The following is a description of a gene set: species: Homo sapiens from publication Chen Y, Wang X (PMID 31504780) Genes predicted to be targets of miRBase v22 microRNA hsa-miR-519a-2-5p, hsa-miR-520b-5p in miRDB v6.0 with MirTarget v4 prediction scores > 80 (high confidence targets). Human Gene Set: MIR519A_2_5P_MIR520B_5P, and this is the list of marker genes: RASAL1, PROM2 (NCBI Gene Id 200480), FUT1, USH1G, PSMD9, CNNM3, ZNF678, SPATA31A1, PCBD2, SLC6A1, SERAC1, HES1, ALG1 (ALG1 chitobiosyldiphosphodolichol beta-mannosyltransferase), PIGR, ZNF619, STARD4, SPATA31A6, CUX2, LRRN3, TNFRSF19, ABLIM2, PARD6B, ING4, ZNF850, IRAK2 (NCBI Gene Id 3656), TRIB1, MICB, SCOC, SLC5A5, SYS1, RAD1, EFCAB5, ZEB2, RNF148, BEND4, IFT81, ATP6V0A2, TIMM50, ITPKB, GINS1, HYKK, TRAF3IP2, CDC14A, GJC1, FBXO31, TENM3, PIWIL4, PPHLN1 (NCBI Gene Id 51535), POLR3C, EXOSC6, BRPF3, PDXDC1, AMMECR1L, ZNF479, PCDH11Y, TCF24, DUSP10, USP28, AP4S1, KCNMB2, SF3B3, PLCXD1, SPATA31A5, IFT70B, SYT1, ATP6V0D2, ZNF326, PCDH11X, PAQR5, APOL6 (NCBI Gene Id 80830), ORAI2, TATDN3, PNO1, ZNF250, EBF1, CXXC5, NEK4 (NCBI Gene Id 8380), KLHL24 (NCBI Gene Id 79965), HMGA2, KBTBD2, ADAMTSL5, GPI, GRM6, TMED7, AK2, CD163, DSC2, TMEM236, WIZ, RPL15, MKX, HCFC1, SHANK2, TP53BP2, TXLNG, ORC1, ZNF638, CASZ1, ELK4, GATA2, CASP10, NYNRIN, CPSF7, SNRPD3, MIS12, FUT9, ZNF99 (NCBI Gene Id 7652), AKAP9, TTC14, SULT1E1, FRY, JADE1, APBB2, SOST, DDX52, SPN, ZNF195, SRPX, IBA57, SMIM3, KLHL5, CTF1, DHX36 (DEAH-box helicase 36), TBC1D9, MTFMT, DEPDC4, SHISA2, KRTAP19-6, TRIQK, PDK3, LRRC51, YPEL5, DUSP19, ADAMTS19, GLRX3, EFCAB2, LRCH4 (leucine rich repeats and calponin homology domain containing 4), FOXL2NB, ERLIN2 (ER lipid raft associated 2), RBM8A, GALNT15, DUOX2, ASH1L, COL12A1, FGD2, SOX6, SLC25A15, PCDHB11, HPSE, SPATA31A3, PRDM16, PAPOLG, CLEC7A, CEBPZOS, SLC4A8, ZC3HAV1L, MET (MET proto-oncogene, receptor tyrosine kinase), CCDC50, EXOC8, TPMT, ZFX, AMTN, RPS20, RFT1, TGS1, RIN2, CLPX, ZNF454, IRF6 (interferon regulatory factor 6), JAZF1, CEP41, UMPS, NTNG2, FZD3, IL12RB1, SIN3A, CBX7 (NCBI Gene Id 23492), UNC45B, PUS7, CDKAL1, VEZF1, SPATA31A7, NCMAP, YIPF5, CCL22, COX15, MOB1A, PGAP1, HSPA12A, PTGR3, SLC11A2, LDHAL6A, ESRP1, MYOZ2, GK5, MMGT1, JCHAIN, JADE2, HMGB2, FGFRL1 (fibroblast growth factor receptor like 1), LURAP1, KCNIP4, CRYBG1, ADGRG1, HSD17B13, TMEM248, ADCY1, PDZD8, IKZF3, PAICS, TOR1AIP2, APELA, RAB11B